The following is a description of a gene set: species: Homo sapiens Genes having at least one occurence of the motif CAGCCTC in their 3' untranslated region. The motif represents putative target (that is, seed match) of human mature miRNA hsa-miR-485-5p (v7.1 miRBase). Human Gene Set: CAGCCTC_MIR4855P, and this is the list of marker genes: RBM4B, ARHGAP32, TRMU, JUND, KCNA6, YWHAG, SUGP1, RBPMS, ZMIZ1, WDTC1, HMGA2, GFI1B, ATRN, FAM53C, CTDNEP1 (CTD nuclear envelope phosphatase 1), PANK3, ELMO2, PHF21A, CDC25A, NELFE, MEF2D, MUC4, SETD2, MPZ, TAOK2, FZD1, THTPA, GABRB3, CHAD, MIR22HG, STX5, YTHDC1, PAX3, ITPRIP, TEX261, ABCB9, CDK18, CEP85, RHBDD2, STC1, NHSL3, TBKBP1, CHD9, ZDHHC5, MSI2 (NCBI Gene Id 124540), INPP5A, GRIN1, PLEC, TTYH2, LZTS3, DUXAP10, EMC10, DCHS1, HIC2, MDGA1, KDSR, SRF, LAMTOR1, DCAF15, LRRC7, ESYT3, LRP4, SOX5, NBEA, TMEM266, DNAJA3, NOVA1, DVL3, HPS4, CCAR2, BAZ2A, NUCB1, TMCC1, ZFP91 (ZFP91 zinc finger protein, atypical E3 ubiquitin ligase), HTRA2, CELSR2, SEMA4G, WNK3, MAN1A1, ABCA9, ARK2C (arkadia (RNF111) C-terminal like ring finger ubiquitin ligase 2C), SPTB, MIER2, VPS26A, POU6F1, PPARGC1A, MAX, ANKFN1, SLC16A2, STRN4, ARL2BP, PHAF1, ASB15, TMEM151A, FKBP4, GBA2 (glucosylceramidase beta 2), NGEF, SYNGR1, IER5L (NCBI Gene Id 445576), TMUB2, CBX6 (chromobox 6), KCNJ11, TRMT9B, OXSR1, TSC22D3, GPR3, ADIPOR2, FOXN2, CHPF, LIN28B, CAMK2N2, TNKS1BP1, SSH2, CADM2, RAB8B, GLCE, SF1, ABHD2, SMDT1, CRB3, RAC1, SLC23A2, DAG1, RASL10A, PDLIM7, SMG1, CNTFR, COPS7B, TTBK1, IGF2BP2, SRPK1, MLLT3, PAK4, PPP1R11, PAK1, SYN3, NRF1 (nuclear respiratory factor 1), GLS2, ZBTB39, LRRC1, QKI, DHX57, SMURF2, CREBRF, TNRC6B, BAHD1